The following is a description of a gene set: species: Homo sapiens Neighborhood of CD53 Human Gene Set: GNF2_CD53 Neighborhood of CD53 CD53 molecule in the GNF2 expression compendium, and this is the list of marker genes: ARHGDIB, FMNL1, DOCK2, TAP1, SP110, IFI16, VAV1, HLA-G, RAC2, WIPF1, HLA-C, ACTR2, PSMB8 (NCBI Gene Id 5696), ACTR3, HLA-F, PTPN6, GIT2, HLA-A, CD53, LSP1, LAPTM5, LRCH4, SELL, GRK6, HLA-B, ELF4, CD48, SASH3, MYD88, STAT6, RPS6KA1, CYBC1, CRLF3, PSME1, PIK3CD, WAS (WASP actin nucleation promoting factor), PSMB9, TRIM22, TUT7, CORO7, INPP5D, FXYD5 (FXYD domain containing ion transport regulator 5), HLA-E, GPSM3, PSMB10, OSTF1, LCP1, PAK2, CORO1A, LIMD2, CSK, CYTIP, B2M, TAPBP, PTPRC, MFNG, PHF11, HCLS1